The following is a description of a gene set: studied in species Homo sapiens Human Gene Set: GSE16522_ANTI_CD3CD28_STIM_VS_UNSTIM_NAIVE_CD8_TCELL_UP Effector cells for adoptive immunotherapy can be generated by in vitro stimulation of naïve or memory subsets of CD8+ T cells. While the characteristics of CD8+ T cell subsets are well defined, the heritable influence of those populations on their effector cell progeny is not well understood. We studied effector cells generated from naïve or central memory CD8+ T cells and found that they retained distinct gene expression signatures and developmental programs. Effector cells derived from central memory cells tended to retain their CD62L+ phenotype, but also to acquire KLRG1, an indicator of cellular senescence. In contrast, the effector cell progeny of naïve cells displayed reduced terminal differentiation, and, following infusion, they displayed greater expansion, cytokine production, and tumor destruction. These data indicate that effector cells retain a gene expression imprint conferred by their naïve or central memory progenitors, and they suggest a strategy for enhancing cancer immunotherapy. Genes up-regulated in comparison of stimulated naive CD8 T cells from pmel-1 mice versus unstimulated naive CD8 T cells from pmel-1 mice. from publication Hinrichs CS, Borman ZA, Cassard L, Gattinoni L, Spolski R, Yu Z, Sanchez-Perez L, Muranski P, Kern SJ, Logun C, Palmer DC, Ji Y, Reger RN, Leonard WJ, Danner RL, Rosenberg SA, Restifo NP (PMID 19805141), and this is the list of marker genes: EIF3E, CASP4, PSMG4, SLC15A1, IPO5, SBDS, ZWINT, EXOSC6, CXCL2, CDIP1, TENT2 (NCBI Gene Id 167153), CCT2, FOXO4, C5orf63, CNOT2 (CCR4-NOT transcription complex subunit 2), AKR1B15, CD70, SPATA25, ABCF1, EIF3C, IL1A, HPCAL4, TBPL1, PCOLCE2, WDR74, APRT, FGB, TBRG4, SLFN12L, CKAP4, HAGH, SLU7, KBTBD12, RFX8, PWP1, FAM43A, SLC25A17, MYO9A, MYH7, MRPL43, LMBRD1, EPHX4, RORC, CFP, DDX47, MLXIPL, ZFAND3, CREBRF, HSF5, PLCXD1, DNAJC7, SNAPC2, HNRNPA1, MTHFD2, PLK2, MACO1, IFI27, CSNK2A2, EYA4, PPP4R4, CCND1, GULP1, CLVS1, YARS1, PHF10, WDR4, OBP2B, GHITM, HAX1, LAPTM4A, RNF4, NFE2, C18orf21, KCTD15, GARS1, NHEJ1, IDO1, PDZRN4 (NCBI Gene Id 29951), B3GALT2, ZC2HC1A, COPS2, RWDD4, FASTKD2, MRPL46, COQ10B, CLCN5, INIP, ZSCAN2, UST, UBE2J2, VSTM4, WARS1, ISY1, INHBA, ZNF622, NWD2, SPATS2L, GPR107, PPM1B, MTAP, PALS2, WDR3, RAP2B, SEPTIN2, NDUFAF4, HLF, APBA1, EN1, NIP7, PINX1, POU3F3, DLGAP3, SLC6A9, CYSRT1, ASNS, NUP43, SARS1, ERG28, ARHGAP35, MID1IP1, GPRASP2, NXT1, TMEM60 (transmembrane protein 60), CDKN1B, CRLF2, NLRP3, UTP4, CCL5, ACTL10, SHMT2, FXR1, EIF3I, LRFN5, TBC1D1, GMPS, PIM3, PHGDH (NCBI Gene Id 94672), HMBOX1, SKIC8, CDC5L, UTP3, CXCL16, SPRYD4, NIBAN1, DIS3, EIF3L (eukaryotic translation initiation factor 3 subunit L), KLHL11, ANKRD50, PTDSS2, C14orf39, REC114 (NCBI Gene Id 283677), INSIG1, PURB, NKAIN1, SQLE, KLHDC3, COPS8, RPP25L, STRA8, CFLAR, GOT1, TLR2, CTRL, ADGB, LRIT1, PSMD14, CAVIN3, NARS1, RARS1, SLC7A1, GTF2B, MRGPRE, AGXT2 (NCBI Gene Id 64902), CYP46A1, BCAT1, C19orf25, SAG, PRPF38A, PSPH, CTPS1, VPS37C, ATXN3, PROM2, NME6, UBE2G1, ZNF296, GPIHBP1, LTBP1, DZANK1, EIF4E, CHRNE, ESAM, EIF6 (eukaryotic translation initiation factor 6), ATP1B1 (ATPase Na+/K+ transporting subunit beta 1), PRM2, ERAS, C4orf17, APPBP2, FCF1, VANGL2